Given this list of marker genes UBA2, DLL4, BMS1, PLEC (plectin), ITGB4, CDKL5, here is a description of the gene set: studied in species Homo sapiens Tactile hypersensitivity Human Gene Set: HP_TACTILE_HYPERSENSITIVITY A decreased tolerance to physical touch.